The following is a description of a gene set: from publication Chen Y, Wang X (PMID 31504780) studied in species Homo sapiens Genes predicted to be targets of miRBase v22 microRNA hsa-miR-210-3p in miRDB v6.0 with MirTarget v4 prediction scores > 80 (high confidence targets). Human Gene Set: MIR210_3P, and this is the list of marker genes: AIFM3, ISCU, MID1IP1, KMT2D, IGF2 (insulin like growth factor 2), SHISAL2B, DENND6A (DENN domain containing 6A), RUNX3, NDUFA4, GALR2, FGFRL1, BDNF